Given this list of marker genes GAS6, TNFRSF21, AKAP12, CERS6, TP53, here is a description of the gene set: Any apoptotic process in an oligodendrocyte. Oligodendrocytes belong to a class of large neuroglial (macroglial) cells in the central nervous system, where they form the insulating myelin sheath of axons. Human Gene Set: GOBP_OLIGODENDROCYTE_APOPTOTIC_PROCESS species: Homo sapiens